Given this list of marker genes CLCNKA, CLCNKB, ITGA8, BSND, FGF20, GFRA1, SLC12A1, RET, MAGED2, WNT9B, GREB1L (NCBI Gene Id 80000), KCNJ1, here is a description of the gene set: Human Gene Set: HP_FETAL_POLYURIA Fetal polyuria species: Homo sapiens Abnormally increased production of urine by the fetus resulting in polyhydramnios.